The following is a description of a gene set: Binding to the small ubiquitin-like protein SUMO. studied in species Homo sapiens Human Gene Set: GOMF_SUMO_BINDING, and this is the list of marker genes: UBA2, PML, USP25, HERC2 (NCBI Gene Id 8924), RNF4, CBX4, TDG, TOLLIP, PELP1, CASP8AP2, HABP4, USPL1, GCNA, SOBP, SIMC1, RNF111, SERBP1